The following is a description of a gene set: Any process that modulates the frequency, rate or extent of the controlled release of a protein from a cell. studied in species Homo sapiens Human Gene Set: GOBP_REGULATION_OF_PROTEIN_SECRETION, and this is the list of marker genes: C2CD2L, IL12A, PPP3CB, GNAO1, PRKN, P2RX7, MLXIPL, BMP8A, TRPM4, APOE, DRD4, NKX6-1, HADH, STX4, GOLPH3L, SNAP25, TRPA1, MIR29B1, STXBP4, TUNAR, ADRA2A, GNAS, G6PC2, PPARG, SLC12A2, GJA5, SLC25A22, TRH, STX1A, PFKFB2, FAM3D, ABCC8, BMP6, RHBDD3, RPH3AL, NNAT, TARDBP (NCBI Gene Id 81927), IL13, SERP1, FOXO1, CLOCK, PARD6A, GPR27, CPT1A, PPARD, MCU, OR51E2, CD2AP, CASR, APBB1, ALOX5, RAP1GDS1, EPHA5, TMED10, ORAI1, KCNA5, HLA-DRB1, PTPN11, CD38, BSG, ACSL4, C1QTNF3, RFX6, CCN3, PRKCA, ATP13A2, NPFF, CHGA, SLC9B2, FOXA2, ENY2, PICK1, F2R, FKBP1B, CCL5, ADTRP, PER2, ERP29, SLC2A2, CYP51A1, SYBU, ITPR1, INHBB, MIR199B, GIPR, IRS1, TRPM5, RHBDF2, TMEM132A, TLR4, ADCY5, ACVR1C, ISL1, DYNLL1, SIDT2, LRRC8A, GCK, TTN, CARTPT, PFKL, CDK16, RAPGEF4, OXCT1, GPR68, ANG, IDH2 (isocitrate dehydrogenase (NADP(+)) 2), DNM1L, NR1H3, IL6, ARF6, CD33, ADAM8, FRMD4A, P3H1, KCNB1, SOX4, DOC2B (double C2 domain beta), MIR766, PSMD9, UNC13B, LEP, TGFB1, DNAJC1, UCP2, BAIAP3, GNAI1, LRP5, TGFB2, MIR199A1, RBP4, HMGCR, MIR93, PRKAR1A, FUT10, SLC30A8, IRS2, PLA2G6, NEO1, F2, SLC16A1 (NCBI Gene Id 6566), SRI, FFAR2, PLCB1, OPRM1, TFAP2B, ADRA2C, PTPN23, BRSK2, ADORA2A, KLF7, UCN3, MYRIP, CD200, NR1H2, EFNA5, TCIRG1, JAK2, BMAL1, RFX3, NR0B2, PDE8B, WLS, SEC24A, DRD3, DPH3, PRKCB, SLC8B1, KRT20, EXPH5, NADK, RAC1, PIM3, CHRM3, GHRL, GPLD1, SYT4 (NCBI Gene Id 6860), PRKCE, APBB3, SIRT4, PHPT1, RHBDF1, GPRC6A, PPID, RAB11FIP3, ABAT, GHSR, FGB, EIPR1, PRKACA, TGFB3, MYOM1, FGG, HIF1A, NR1D1, GNA11, FUT11, VEGFC, GPER1 (NCBI Gene Id 2852), ABCG1, SYTL4, CFTR, GCG, ABCA12, VSNL1, IGF1 (insulin like growth factor 1), PPIA, SYT7, IFNG, HCAR2, NEUROD1, MYH10, IL1B (interleukin 1 beta), TREM2, ADCY8, IL12B, KCNN4, PLA2G1B, SAA1, NR1H4, PDX1, GNAZ, GIP, SREBF1, TNF, DRD2, TCF7L2 (NCBI Gene Id 6934), REST, MIR19A, GOLPH3, RAPGEF3, INS, SIRT6, MIR30C1, VPS35, ANKRD1 (NCBI Gene Id 27063), BAD, HNF4A, ADAM9, FGA (fibrinogen alpha chain), TLR2, RSAD2, CELA2A, RAB11FIP5, MYO18A, F2RL1, MPC2, ENSA, KCNK16, CAPN10, ACHE, CRH, SSTR5, NOS2 (NCBI Gene Id 4843), TM7SF3, ZBED6, IER3IP1, PCK2, ARFIP1, F2RL2, NLGN2, PFKM, UQCC2, SERGEF, NMU, AACS, MIR19B1 (NCBI Gene Id 406980), OSBP, C1QTNF12 (C1q and TNF related 12), SIRT3, MIR146A, JAGN1, BLK, IL1A, ANO1, NDUFAF2, FFAR1 (free fatty acid receptor 1), MIDN, GLUD1, KCNJ11, MTNR1B, RAB11FIP1